The following is a description of a gene set: from publication Chen Y, Wang X (PMID 31504780) species: Homo sapiens Human Gene Set: MIR6074 Genes predicted to be targets of miRBase v22 microRNA hsa-miR-6074 in miRDB v6.0 with MirTarget v4 prediction scores > 80 (high confidence targets)., and this is the list of marker genes: PCGF5, NAA15, SETBP1, CXCL6, MAN1C1, SFMBT1, ODC1, POLK (NCBI Gene Id 51426), DUSP16, ZNF816, SOCS4, STK17B, ZNF283, BRINP3, TTC9, MSTN, YAF2, MEP1A, TRAPPC8, DCUN1D5, OR9Q1, SLC37A3, GNAI3 (NCBI Gene Id 2773), ZNF780B, FAM241A, MMD, FBXO38, SGK3, CDKN2C, TENT5A, CD2AP, DDX53, PHIP, PIK3C2A, HTR2A, SYNJ1, RXFP1, TNPO1, GABRG2, MGA, ST8SIA4, SYT16, IDE, PWWP2A, TRDN, SLC38A2, FUT9, NDUFA5, GPAT3, ELAVL2, DAAM2, ISOC1, CDYL2, HPGD, SNX31, SPAG9, RBM7, GOLGA4, GOLIM4, RASGRP2, TMEM135, ADH7, MACIR, NAALADL2, SAP18 (Sin3A associated protein 18), ARMC2, TRIM38, SPATA6 (NCBI Gene Id 54558), SERPINB10, IRAK1BP1, CALHM5, ANKRD20A1, ERAP1 (endoplasmic reticulum aminopeptidase 1), ERRFI1, RSBN1, ITGB8, LRPPRC, NUDT7, IRF2, CDH19 (cadherin 19), GPR180, CFAP97 (cilia and flagella associated protein 97), LMO7DN, ABCC9, THRB, G6PC2, MELK, ZBTB10, SNX13, ANKRD20A2P, ZC3H14, AFF4, SUCLG2, ZNF624, FANCL, PDP1, DCLK1, TULP3, ZNF844, CKAP2, PRG4, DLC1, CADM2, RHOT1, ATG5, SSPN, ENPP3, RNF121 (NCBI Gene Id 95997), SAMD5, AIFM1, AQR, ARL15, TMEM243, KRT20, PRDM13, SMAD2, RFX7, MRPL17, ZNF658 (NCBI Gene Id 26149), PNISR, ZNF605, MIPOL1, PTGER3, CLK2, CDC6, SORCS3, SGIP1, ZNF28, MTERF3, NEK2, PSD3, GXYLT1, SLC6A15, OAT, NCKAP5, UTP14C (NCBI Gene Id 9724), NBN, PIK3CA, PYGO1, RAB44, KCNV1, RP1L1, TUSC1, USF3, PHF20L1, TNKS2, ZNF423, ARMCX3, VNN1, CREBBP, R3HDM2, RBSN, AQP4, SP3, SNTN (sentan, cilia apical structure protein), FGFR1OP2, FAXC, KLF10, NIP7 (NCBI Gene Id 51388), PTPRN2, NLGN1, CHD9, NTNG1, AK6, UBE2W, PCDH18, MAP3K2, EVI5, MMP13, EP300, TENT4B, GNPNAT1, IRF2BPL, TMEM108, FRMD3, CHD1, ARFIP1, NAA30, MSANTD4, COL4A4, ZNF148, ANKRD20A3P, ZBTB21, ITFG1, IL22RA2, SLC35F4, FBXL17, ZNF37A, ZFYVE16, RHOU, RIPOR2, CROT, ZNF124, SHC3, ELAVL4, EPHA5, CXADR, LRRCC1, STAU2, TSPAN2, DST, BEX1, CCZ1B, ARFGEF1, ANKRD20A4P, SCOC, DIPK2A, SOX5, AKAP11, MCTS1, TRIP12, KLHL2, FOXD3, A1CF, ATP5MG (NCBI Gene Id 10632), ALG10, GRIK3, MAP9, ADCYAP1, FANCF, GSE1, GTF2A1L, CYBRD1, ITGA4, CALCRL (NCBI Gene Id 10203), CNGB1, ZBTB25 (NCBI Gene Id 7597), ZSWIM2, CFL2, ZNF680, NPY2R, GTF2A1, STON1-GTF2A1L, BRWD1, AKIRIN1, GLRA3, TRIM23, CDC40, AP1S3, GRIA4, CYBB, RPS6KA6, FBXO30, ACTR3, ERO1B, LPP, MCM8, SGO1, DNAL1 (NCBI Gene Id 83544), PEX11B, RAB18, ZC3HAV1L, ZNF326, JUNB, PRDM5, RFX3, NCAPG2, HIVEP1, ANK2, GNPDA2, RRM2B, TMEM236 (transmembrane protein 236), CDS1, KIF11, KIAA1328, PDIA6, WDFY3, KDM4C, SELENOT, DIP2B, MARCHF7, PTPRJ, BAG4, QKI, CHUK, STRAP